The following is a description of a gene set: Human Gene Set: GSE360_DC_VS_MAC_DN species: Homo sapiens Monocyte-derived dendritic cells (DC) and macrophages (MΦ) generated in vitro from the same individual blood donors were exposed to five different pathogens, and gene expression profiles were assessed by microarray analysis. Responses to Mycobacterium tuberculosis and to phylogenetically distinct protozoan (Leishmania major, L. donovani, Toxoplasma gondii) and helminth (Brugia malayi) parasites were examined, each of which produces chronic infections in humans yet vary considerably in the nature of the immune responses they trigger. Genes down-regulated in comparison of dendritic cells (DC) versus untreated macrophages. from publication Chaussabel D, Semnani RT, McDowell MA, Sacks D, Sher A, Nutman TB (PMID 12663451), and this is the list of marker genes: P2RX7, SLC6A11, ERC2-IT1, ZNF785, NUDT1, PCDHGA8, ECD, ZFHX3, SMPD1, DENND2B, MRPL40, MYDGF, CDK10, PEX12, GNA13, BAD, DLEC1, PRDX4, CD52, NDUFS3, SEM1, STK19, OGFR, RPS24, RUVBL1, ZSWIM8, PRDX2, RRBP1, RAB3GAP1, UGCG, CNOT2, IMPDH2, PRDX1, HLA-DMB, GPR19, AATK, NFYA, GRB2, RPH3A, MT1X, CDC16, ADA, CARD10, PFN2, SREBF2, PDE1A, APOBEC3C, SEPTIN11, TSFM, KBTBD2, FCAR, FLT3, TYMP, SPINK4, SPC25, SULF1, ARHGAP4, CRABP2, IRF7, NSDHL, RPS26, LSM7, CP, PYGM, ACVR2A, SPAG7, NHP2, PPP1R11, NREP, NDUFV1-DT, TTLL3, MAPT, RFX2 (regulatory factor X2), FYN, PTPRCAP, FOXO3, PBX2, PLP2, PLXNC1, LDHA, CXCL8, PGAP4, ANGPTL7, ABCB7, TNNT1, SUSD5, TGFB1, P2RY10, IMP4, USF2, CADM1, TRIM44, HOXC5, S100A9, ATF3, CKAP5, OAS2, RUNX3, VAMP3, TBCB, SLC16A5, RRP7A, ME1, SNX17, MYH6, TNPO3, OVOL2, SLC7A5, GBX2, DYNLL1, RALB, TRAPPC12, SAPCD1, KHNYN, PIGR (NCBI Gene Id 5284), FAT2, RPS6KA2, SNRPD2, FOXE1, GAS7, DNAJC13, SERPINH1, GCHFR, NFKB1, S100A10, AURKB, HSPB3, RPL23, BTRC, DHRS1, BST2, IGBP1, ATF4, EMP3, KDM7A, BTN3A1, FSHR, ILK, SLC25A1, MAGEA4 (NCBI Gene Id 4103), IFI16, TIMP2, ATP1B2, PHF1, ZNF280B, SSNA1, CAP2, NGDN, SEC13, POT1, AMHR2 (NCBI Gene Id 269), IGFBP5, IQSEC2, SCARB2, ANXA6, RBCK1, CPNE6, RTL8C, RABAC1, ERF, DDX52, IGHMBP2, SYT5, PSMB2, TSC22D3, RPS6, ATP6V0C, ATP6V1H, ZNF253, PTPN6, EPB41L3, GPR3, ARR3, CD14, DAXX, PLK3, DNAJC4, GNL2, MEF2D, NACA, GANAB, MUC6, GNRH2, MAFF, ATP8B1, TSNAX, DLGAP1, C6orf47, CCNI, PPP4C, RETREG3, GLA (NCBI Gene Id 2717), CDK2AP2, PSME2, HIVEP2, MYO1F, KIF3B, TPD52L2